Given this list of marker genes CHD7, SLC2A2, GNAS, PARK7, BAD, SLC30A8 (solute carrier family 30 member 8), STX4, PFKM, CPLX3, TCF7L2, SLC8B1, RAF1, GAL, IRS2, ISL1, RAB3A, GHRL, CD209, CCN3, TCIRG1, ACSL4, PIM3, FOXA2, UCP2, MC4R, PFKFB2, NPY2R, SLC9B2, RAPGEF3, PFKL, NR0B2, GPR119, PRKCA, ADCY5, SMPD3, FGB, CCL5, NPFF, SIRT4, TRH (NCBI Gene Id 7200), OXCT1, C2CD2L, ABCC4, STX1A, JAK2, FAM3B, TAP2, TFAP2B, GCK, PHPT1, IL1RN, GRP, HTR2C, PTPRN, VGF, NMU, GHRH, MTNR1B, CHRM3, EXOC3L1, KCNK16, CPT1A, TRPV1, GPR27, GPLD1, ABCC1, NLGN2, ENSA, PCLO, ILDR2, PRKACA, BAIAP3, RPH3AL, CAMK2G, SRI, FAM3D, TNFSF11, PTPN11, DISP1, RASL10B, CCDC186, SLC16A1, RAB11FIP2, LRP5, VSNL1, TM7SF3, TARDBP, ADCYAP1, CDH17, SLC15A3, ADORA1, IL6, ENY2, ILDR1, PRKD1, CLEC4M, REST, F2, FOXO1, GABBR1, NR1D1, NDUFAF2 (NCBI Gene Id 91942), CPLX1, CPE, FGA, UBE2Q1, RAB11FIP5, LEP, FKBP1B, PICK1, AQP1, PER2, ABCC5, KLF7, SLC16A2, MLXIPL, RBM4, SLC7A11, BLK, SOX4, MYRIP, CA2, HNF1B, PRKN, IL1B, ADCY8, GNA11, SLC15A1, SELENOT, ZBED6, GIP, PRKCE, GNAZ (NCBI Gene Id 2781), KCNA5, SIRT3 (NCBI Gene Id 23410), ITSN1, SIRT6, MPC2, CD38, ACVR2B, RAC1, IFNG, CRH, RFX3, TOR2A, MGST1, ADRA2A, PLA2G6, NR1H4, PAX8, INHBB, STXBP3, SLC16A10, DYNLL1, SLC13A3, PRKAR1A, PDX1, NEUROD1, EDN3, NOS2, DRD2, BMP8A, C1QTNF12, SLC26A6, GHSR, CYB5R4, ABCA1, HFE, GIPR, TACR2, RBP4, ABAT, MCU, INS, TRPV4, AACS (NCBI Gene Id 65985), SLC15A5, SCT, CLTRN, SMAD2, GCG, UQCC2 (NCBI Gene Id 84300), HMGA2, SLC25A40, SREBF1, HNF4A, ORAI1, ECRG4, EFNA5, SLC15A4, TFR2, RAB1A, F2RL2, MMP7, ADRA2C, CLOCK, S100A8, SNX19 (sorting nexin 19), CHGA, UCN3, EIPR1, TRPM5, PRKCB, TUNAR, SLC15A2, NADK, TRPM4, SYBU, HADH, ACVR1C, CAPN10 (calpain 10), MIDN, OSBP, MAFA, VIP, SLC25A22, FFAR4, NHERF1, NNAT, NKX6-1, SNAP25, GPER1 (G protein-coupled estrogen receptor 1), DOC2B, CD74, ABCC8, FFAR3, FGG, ABCB9, GLUD1, F2RL1, IRS1 (NCBI Gene Id 3667), ALOX5, CRHBP (NCBI Gene Id 1393), APLN, PLCB1, LRRC8A, EPHA5, CRHR1, PDE8B, TAP1, AIMP1 (aminoacyl tRNA synthetase complex interacting multifunctional protein 1), FFAR2, GPR68, RAB8B, STXBP4, FAM3A, JAGN1, CARTPT, ITPR1, PCK2, SLC25A39, RAB11B, KCNB1, CWH43, TRPA1, G6PC2, PSMD9, GNAO1, MFSD1, PPARD, CELA2A, RAPGEF4, GJA1, BMAL1, RIMS2, PPP3CB, SIDT2, SYTL4, PASK, HLA-DRB1, CFTR (NCBI Gene Id 1080), SSTR5, HIF1A, PTPRN2, ABCA12, GNAI1, TNF, BRSK2, HNF1A, KCNJ11, SERP1, EDN1 (NCBI Gene Id 1906), CASR, UCN, ANO1, GPRC6A, GHRHR, RFX6, FFAR1, SYT7, CDK16, here is a description of the gene set: species: Homo sapiens The directed movement of peptides, compounds of two or more amino acids where the alpha carboxyl group of one is bound to the alpha amino group of another, into, out of or within a cell, or between cells, by means of some agent such as a transporter or pore. Human Gene Set: GOBP_PEPTIDE_TRANSPORT